Given this list of marker genes TRAF6, MAPK8, CD40LG, TRAF2, TRAF3, JAK3, RELA, JUN, TNFAIP3, BIRC2, AKT1, MAPK11, STAT5A, NFKBIA, MAPK14, CD40, MYC, NFKB1, TRAF1, MAP2K4, BIRC3, TDP2, FCAMR, CBLB, MAP3K1, C4BPA, IL4, MAPK9, MAPK10, BCL2L1, MAP3K14, here is a description of the gene set: from publication Schaefer CF, Anthony K, Krupa S, Buchoff J, Day M, Hannay T, Buetow KH (PMID 18832364) Human Gene Set: PID_CD40_PATHWAY CD40/CD40L signaling studied in species Homo sapiens